Given this list of marker genes Smoc2 (NCBI Gene Id 80628), Dstyk, Ctnnb1, Nrxn1 (neurexin I), Fgfbp1, Pdgfb, Fgfbp3, Prkd2 (NCBI Gene Id 232912), Nptn, Itgb1, here is a description of the gene set: Any process that activates or increases the frequency, rate or extent of fibroblast growth factor receptor signaling pathway activity. species: Mus musculus Mouse Gene Set: GOBP_POSITIVE_REGULATION_OF_FIBROBLAST_GROWTH_FACTOR_RECEPTOR_SIGNALING_PATHWAY